The following is a description of a gene set: Any process that increases the rate, frequency, or extent of epithelial to mesenchymal transition. Epithelial to mesenchymal transition is where an epithelial cell loses apical/basolateral polarity, severs intercellular adhesive junctions, degrades basement membrane components and becomes a migratory mesenchymal cell. species: Homo sapiens Human Gene Set: GOBP_POSITIVE_REGULATION_OF_EPITHELIAL_TO_MESENCHYMAL_TRANSITION, and this is the list of marker genes: HDAC2, LEF1, NOTCH1, SMAD3, TBX20, ISL1, MIR222, MDK, AXIN2, MTOR, COL1A1, DAB2, TGFBR2, TGFBR1, OLFM1 (NCBI Gene Id 22825), WWTR1, BMP4 (NCBI Gene Id 652), MIR519D (NCBI Gene Id 574480), ACVR1, FOXC1, SMAD2, MIR221, PTK2, KDM1A, GCNT2, RGCC, TGFB2, SERPINB3, CRB2, EZH2, LRG1, TCF7L2, IL6, ALX1, TGFB1I1, TWIST1, IL1B, FERMT2, SMAD4, PDPN, AGT, SNAI1, BMP7, TGFB3, TNXB, EMP2, SDCBP, ADAM8, LOXL2, GLIPR2, TIAM1, TGFB1, CTNNB1, ZNF703, BAMBI, BCL9L, JAG1, MIR21, ENG, BMP2